The following is a description of a gene set: studied in species Mus musculus Mouse Gene Set: GOBP_CELL_CELL_JUNCTION_MAINTENANCE The maintenance of junctions between cells., and this is the list of marker genes: Epb41l3, Cntnap1, Inava, Mtss1, Pard6a, Whrn, Kirrel1, Mpz, Lypd10, Shroom2, Camsap3, Pkp2, Fermt2, Lypd11, Csf1r, Prtn3, Cd177, Pkp1, Plekha7, Tjp1, F2r, Dsc1, Afdn, F2rl1, Kifc3